The following is a description of a gene set: studied in species Homo sapiens Genes up-regulated in the common lymphoid progenitor (CLP, defined as CD34+CD38-CD7+) compared to a multipotent cord blood cell (defined as CD34+CD38+CD7-). from publication Hoebeke I, De Smedt M, Stolz F, Pike-Overzet K, Staal FJ, Plum J, Leclercq G (PMID 17170726) Human Gene Set: HOEBEKE_LYMPHOID_STEM_CELL_UP Hematopoietic stem cells in the bone marrow (BM) give rise to all blood cells. According to the classic model of hematopoiesis, the differentiation paths leading to the myeloid and lymphoid lineages segregate early. A candidate 'common lymphoid progenitor' (CLP) has been isolated from CD34(+)CD38(-) human cord blood cells based on CD7 expression. Here, we confirm the B- and NK-differentiation potential of CD34(+)CD38(-)CD7(+) cells and show in addition that this population has strong capacity to differentiate into T cells. As CD34(+)CD38(-)CD7(+) cells are virtually devoid of myeloid differentiation potential, these cells represent true CLPs. To unravel the molecular mechanisms underlying lymphoid commitment, we performed genome-wide gene expression profiling on sorted CD34(+)CD38(-)CD7(+) and CD34(+)CD38(-)CD7(-) cells. Interestingly, lymphoid-affiliated genes were mainly upregulated in the CD7(+) population, while myeloid-specific genes were downregulated. This supports the hypothesis that lineage commitment is accompanied by the shutdown of inappropriate gene expression and the upregulation of lineage-specific genes. In addition, we identified several highly expressed genes that have not been described in hematopoiesis before., and this is the list of marker genes: SH3TC1, KMT5B, PRKCB (protein kinase C beta), SLC24A3, TNS3, CHD3, HLX, RBM39, PNN, NLRP1, MSL1, EIF4A1, NACA, TCF4, ITSN2, SLC33A1, LRRFIP1, TRAF3IP3, LUNAR1 (leukemia-associated non-coding IGF1R activator RNA 1), P2RY14, UBR2, TENT4A, KNTC1, KDM3A, SLC35E2B, HNRNPA1, IRF8, PGGHG, NUDT3, TRIB2, SATB1, METTL3, MCM3AP, TRAF4, ABCA1, RUNX3, CCNL1 (NCBI Gene Id 57018), RPS6KA2, CCR9, RAB14 (RAB14, member RAS oncogene family), PLXND1, NF1, BAALC, LPIN1, USP34, STK32B, SETBP1, PALLD, SFPQ, KIAA0087, RBBP6, RERE, ADAM28, IGHM, DOCK1, NCOR2, ATR, BASP1, TPR, BCL6, KLF3-AS1, COBL, ADA, IQSEC1, DPEP2, SLC2A5, MED13L, SF3B1, TBCD, MEF2A, SMARCA4, MACF1, FAM30A, SCN3A, TNFAIP2, TMEM41B, TRIM33, BTK, MN1, ARHGAP25, C11orf21, CD99P1, ITGA4, ARHGAP45, OSBPL3, SPON1, ITIH4, SLC38A1, ADGRE2, TARBP1, TRAF5, NPIPB3, TNFAIP3, RAB31, SETD5, DDX21, CYTH4, EVL